Given this list of marker genes TEX14 (testis expressed 14, intercellular bridge forming factor), XRCC2 (X-ray repair cross complementing 2), BRCC3, FANCE, TERB2, FKBP6, CDY2A, NNT, DDX3Y, RPS4Y2, GNRHR, STAR, RAD51C, WT1, DAZ4, KISS1R, HSFY1, SCP2, MCM8, UBE2T, MC2R, HJV, MSH4, FANCM, VCY, TXNRD2, TEX11, PROK2, BRIP1, STK11, BMP2, HS6ST1, LHB, KASH5, MEIOB, PROKR2, ANK1, DNHD1, TAF4B (NCBI Gene Id 6875), SRY, PALB2, GATA4, NR5A1, CEP19 (centrosomal protein 19), FANCB, CDY1, KISS1, RNF212, FANCI, MAP3K1, KDM5D (NCBI Gene Id 9773), TDRD9, MAD2L2, WNT4, FANCD2, SOX9, DNAH9, TEX15, SPRY4, MRAP, RAD51, ZFPM2, TERB1, SLX4, KIT, DHX37, NR0B1, MSH5, HSD3B2, CCDC34, ERCC4, FANCC, ADGRG2, RFWD3, CT55, BRCA1, GBA1, AR, STAG3, DNAH10, NANOS1, OCRL, VAMP7, SYCP3, CHD7, WDR11, FANCL, CFTR, PNLDC1, M1AP, DAZ1, SPATA22 (NCBI Gene Id 84690), FSHB, RBMY1A1, MOV10L1, SEMA3A, SOHLH1, DUSP6, SLC29A3, TACR3, KLHL10, FANCA, FBXO43, CATSPER2, FANCF, C14orf39, USP9Y, TAC3, CLDN2, SYCE1, STEAP3, FGF8, BCL10, FGF17 (fibroblast growth factor 17, NCBI Gene Id 8822), NSMF, BPY2, HNF1B, STRC, ANOS1, FANCG, DAZ3, RPL10L, NHLH2 (NCBI Gene Id 90888), TSPY1, HFE, GCNA, XKRY, ZSWIM7, SPINK2, CATIP, FGFR1, WWOX, FGFR3, DAZ2, BRCA2, SHOC1, GNRH1, BLM, ZMYND15, PDHA2, SPAG17, here is a description of the gene set: species: Homo sapiens Human Gene Set: HP_AZOOSPERMIA Absence of any measurable level of sperm,whereby spermatozoa cannot be observed even after centrifugation of the semen pellet. Azoospermia